Given this list of marker genes ITGA8, SHISA9, SLC9A5, DDN, GRIA1, SHISA7, KCNC3, ATP6AP2, SHISA6, SHISA8 (shisa family member 8), CLCN2, PPP1R9B, DAGLA, ATP2B2, TRPV1, GPER1 (G protein-coupled estrogen receptor 1), here is a description of the gene set: The portion of the plasma membrane surrounding a dendritic spine. Human Gene Set: GOCC_DENDRITIC_SPINE_MEMBRANE species: Homo sapiens